Given this list of marker genes Rdh7, Rdh16f2, Rdh9, Hsd17b6, Hsd17b10, Rdh5, Rdh1, Rdh16, Rdh19, Dhrs9, here is a description of the gene set: Mouse Gene Set: GOMF_ANDROSTAN_3_ALPHA_17_BETA_DIOL_DEHYDROGENASE_NADPLUS_ACTIVITY Catalysis of the reaction: NAD+ + androstan-3-alpha,17-beta-diol = 17-beta-hydroxyandrostan-3-one + NADH + H+. species: Mus musculus